Given this list of marker genes Irgm2, Tap1, Socs1, Samhd1, Ifi47, Ccr1, Gbp3, Igtp, Slfn1, Irgm1, Irf8, Gbp2, Calhm6, Gda, Gbp7, here is a description of the gene set: from publication Cui A, Huang T, Li S, Ma A, Pérez JL, Sander C, Keskin DB, Wu CJ, Fraenkel E, Hacohen N (PMID 38057668) Mouse Gene Set: CUI_MONOCYTE_IL12_RESPONSE_UP Genes positively differentially expressed in cell type: Monocyte upon treatment with cytokine: IL-12 in mouse lymph nodes in vivo. species: Mus musculus Cytokines mediate cell-cell communication in the immune system and represent important therapeutic targets. A myriad of studies have highlighted their central role in immune function, yet we lack a global view of the cellular responses of each immune cell type to each cytokine. To address this gap, the authors created the Immune Dictionary, a compendium of single-cell transcriptomic profiles of more than 17 immune cell types in response to each of 86 cytokines (>1,400 cytokine-cell type combinations) in mouse lymph nodes in vivo. A cytokine-centric view of the dictionary revealed that most cytokines induce highly cell-type-specific responses. For example, the inflammatory cytokine interleukin-1β induces distinct gene programmes in almost every cell type. A cell-type-centric view of the dictionary identified more than 66 cytokine-driven cellular polarization states across immune cell types, including previously uncharacterized states such as an interleukin-18-induced polyfunctional natural killer cell state.